Given this list of marker genes Cyp4f15, Gpx4, Cyp4a29, Hpgds, Alox8, Cyp4a32, Cyp4a31, Mapkapk2, Tbxas1, Cyp4a30b, Ptges, Alox5, Pon3, Alox15, Cyp4a14, Cyp4f14, Pla2g4a, Cyp2c65, Cbr1, Cyp2c66, Cyp1a2, Lta4h, Cyp4f18, Cyp4a10, Ptgs2, Cyp2u1 (cytochrome P450, family 2, subfamily u, polypeptide 1, NCBI Gene Id 71519), Aloxe3, Akr1c6, Cyp4a12b, Ptgds (NCBI Gene Id 19215), Gpx1, Cyp4f39, Ggt5, Ptgis, Ptges2, Cyp4f40, Cyp4a12a, Ptges3, Ggt1, Awat1 (acyl-CoA wax alcohol acyltransferase 1), Alox12b, Cyp8b1 (NCBI Gene Id 13124), Cyp1a1, Pon1, Akr1c21, Ltc4s, Dpep1, Faah, Cyp1b1, Gpx2, Dpep2, Akr1c20, Cyp2j6, Alox12, Cyp4b1, Pon2, Ptgs1, Alox5ap, Abcc1, Ephx2, here is a description of the gene set: species: Mus musculus Mouse Gene Set: REACTOME_ARACHIDONATE_METABOLISM Arachidonate metabolism